Given this list of marker genes XRCC6, LIG1, XRCC5, FEN1, BANF1, XRCC4, rev, CCR5, vif, vpr, vpu, gag-pol, PSIP1, KPNA1, HMGA1, CXCR4, gag, PPIA, nef, CD4, LIG4, env, here is a description of the gene set: species: Homo sapiens part of: HIV Life Cycle Reactome Pathway: Early Phase of HIV Life Cycle In the <b>early phase </b> of HIV lifecycle, an active virion binds and enters a target cell mainly by specific interactions of the viral envelope proteins with host cell surface receptors. The virion core is uncoated to expose a viral nucleoprotein complex containing RNA and viral proteins. HIV RNA genome is reverse transcribed by the viral Reverse Transcriptase to form a cDNA copy, that gets inserted into host cell DNA. The viral Integrase enzyme is vital to carry out the integration of the viral cDNA into the host genome. The host DNA repair enzymes probably repair the breaks in DNA at the sites of integration.